The following is a description of a gene set: Serotonin (5-HT) is a monoamine neurotransmitter that plays an important role as a modulator of anger, aggression, body temperature, mood, sleep, sexuality, appetite, metabolism, as well as stimulating vomiting. Several classes of drugs target the 5-HT system including some antidepressants, antipsychotics, anxiolytics, antiemetics and antimigraine drugs. The activity of 5-HT is modulated by 5-HT receptors, made up of seven families (5-HT1-7). All but 5-HT3 (ligand-gated ion channel) are GPCRs and these receptors bind different G proteins resulting in differing outcomes (Hoyer D et al, 1994; Kitson SL, 2007). Reactome Pathway: Serotonin receptors species: Homo sapiens part of: Amine ligand-binding receptors, and this is the list of marker genes: HTR6, HTR2C, HTR1B, HTR1D, HTR5A, HTR4, HTR7, HTR2A, HTR1F, HTR2B, HTR1E, HTR1A